Given this list of marker genes Apobec1, Dhx34, Rbm7, Rida, Pan3, Pnrc1, Tirap, Hspa1b, Cnot1, Lsm6, Mus81, Cnot2, Piwil4, Il17a, Rc3h2 (ring finger and CCCH-type zinc finger domains 2), Fto, Mov10, Pan2, Btg2 (BTG anti-proliferation factor 2), Exosc9, Ikbke, Dnd1, Pcbp4, Ncbp1, Ttc5, Tnrc6b, Fastkd3, Nsun2, Eif4a3l2, Zc3hav1, Rexo4, Setmar, Zpr1, Igfbp3, Il6, Rnaseh2c, Nudt12, Cnot7, Mettl16 (NCBI Gene Id 76970), Dnase2b (deoxyribonuclease II beta), Fastk, Gtpbp1, Zfp36l3, Traf2, Pias4, Fastkd2, Upf2, Magoh, Dnase1l1, Sidt2, Ssb, Eloc, Larp4b, Exosc6, Dnase1, Rnasel, Mettl3, Lsm5, Zc3h18, Mtrex, Rnaseh2a, Khsrp, Dcp1a, Upf3b, Mir451a, Ncbp2, Tob1, Mir7578 (NCBI Gene Id 102466836), Ythdf2, Edc4, Mrto4, Dazl, Dnase2a, Endog, Smg7, Dcps, Hnf4aos, Smg1, Npm1, Igf2bp2, Blvra, Larp1, Smg8, Apex1, E2f1, Dffa, Dicer1, Alkbh5, Eif4a3, Caprin1, Wdr82, Ang, Fastkd1, Lsm4, Mirlet7c-2, Cdkn2a, Zfp36l2, Eif4a3l1 (eukaryotic translation initiation factor 4A3 like 1), Dis3l2 (NCBI Gene Id 77551), Tent5d, Gtsf1, Cpeb3, Fam76b, Fbh1 (F-box DNA helicase 1), Csdc2, Tut4, Fxr1, Tnf, Mapkapk2, Elavl4, Mir144, Gata5, Ythdf1, Gas5, Gspt1, Cnot10, Atm, Rnaseh1, Skic8, Edc3, Boll, Hnrnpab, Mtpap, Zc3h4, Ybx1, Cidea, Patl2, Nlrp5, Upf3a, Vegfa, Dnase1l3, Syncrip, Dna2, Brf1, Thrap3, Zar1, Ago1, Gtpbp2, Trex1, Samd4, Exog, Upf1, Mlh1, Nudt16l2 (nudix hydrolase 16 like 2), Rc3h1, Piwil2, Pcid2, Trnt1, Srsf1, Secisbp2, Nbdy, Ang4, Exosc8, Meioc, Tnrc6c, Rbm47, Mir451b, Ctif, Mir196b, Casc3, Dhx9, Mirlet7b, Zc3h12d, Xrn1 (5'-3' exoribonuclease 1), Exosc7, Pabpc1, Magohb, Rock2, Zfp36, Lsm1, Mex3d, Rnps1, Vps54, Hspa1a, Tnfrsf1b, Rnaset2b (NCBI Gene Id 98070), Tent5b, Mtor (mechanistic target of rapamycin kinase), Ern2, Paip1, Isg20, Apaf1, Exosc4, Bax, Slfn8, Scgb1a1, Tesk1, Mirlet7c-1, Ddx5, Senp1, Dffb, Exosc5, Eri1, Hbs1l, Dis3, Pnrc2, Pkp3, Skic2, Pnpt1, Gdnf, Rbm8a2, Pde12, Carhsp1 (calcium regulated heat stable protein 1), Vip, Nanos3, Hnrnpu, Cnot6l, Etf1, Celf1, Dkc1, Ythdf3, Fmr1, Tut7, Arid5a, Rbm10, Pkp1, Exosc10, Taf15, Nbas, Angel2 (angel homolog 2), Pum1, Patl1, Grsf1 (NCBI Gene Id 97246), Aifm1, Dcp1b, Piwil1, Cnot9, Cirbp, Igf2bp1, Nanos1 (nanos C2HC-type zinc finger 1), Mir466l, Rgn, Zc3h12a, Tent2, Gigyf2, Lsm7, Eif4enif1, Tut1, Trdmt1, Smg5, Tent4b (terminal nucleotidyltransferase 4B), Fastkd5, Nrde2, Mettl1, Rbm8a, Csde1, Traf3ip2, Slfn9, Rbm46, Cnot8, Hnrnpc, Hsf1, Pop1, Rock1, Cnot6, Lrpprc (NCBI Gene Id 97785), A1cf, Calcr, Noct, Rbm24, Hnrnpr, Slfn2, Parn, Lsm14b, Myd88, Cacng7, Snd1, Exosc2, Polr2g, Sgms1os1, Elavl1 (NCBI Gene Id 97501), Cnot3, Nsun4, Dhx36, Oas2, Dis3l, Tent4a, Slirp, Dbr1, Pym1, Slfn14, Zcchc7, Skic3, Nudt16, Nanos2, Prr5l, Supv3l1, Eif3e, Nmnat1, Mir196a-2, Pabpc4, Dnase1l2, Igf2bp3, Rbm33, Fen1, Hnrnpd, Zswim8, Pnldc1, Ago2, Phax, Smg6, Gspt2, Nicol1, Trim71, Tent5c, Foxl2, Ptbp1, Dxo, Vim, Pelo, Tent5a, Zc3h14, Elob, Plekhn1, Ago3, Dcp2, Lsm2, Mir196a-1, Exosc3, Traf5, Nudt16l1 (NCBI Gene Id 77104), Trex2, Fxr2, Zcchc17, Tardbp, Tnrc6a, Qki, Mettl14, Zhx2, Fus, Trir, Samd4b, Smg9, Exosc1, Axin2, Xrn2, Zfp36l1, Ybx2, Pum2, Ddx49, Ago4, Slc11a1, Hnrnpa0, Lin28b (NCBI Gene Id 69965), Rbm38, Pabpn1l, Rnaset2a, Rnaseh2b, Naf1, Lin28a, Tbrg4, here is a description of the gene set: The cellular DNA metabolic process resulting in the breakdown of a nucleic acid. studied in species Mus musculus Mouse Gene Set: GOBP_NUCLEIC_ACID_CATABOLIC_PROCESS